The following is a description of a gene set: studied in species Mus musculus part of: Glycosphingolipid metabolism electronically inferred by orthology from the curated human pathway Reactome Pathway: Glycosphingolipid biosynthesis This event has been computationally inferred from an event that has been demonstrated in another species.<p>The inference is based on the homology mapping from PANTHER. Briefly, reactions for which all involved PhysicalEntities (in input, output and catalyst) have a mapped orthologue/paralogue (for complexes at least 75% of components must have a mapping) are inferred to the other species., and this is the list of marker genes: B3galnt1, St8sia5, Cerk, St3gal3, St3gal2, B4galt6, St3gal5, B3galt4, Fut2, St6galnac6 (NCBI Gene Id 50935), Fut1 (NCBI Gene Id 14343)